Given this list of marker genes ATR, PCNT, ERCC6, SRCAP, ERCC8, EIF2AK3 (eukaryotic translation initiation factor 2 alpha kinase 3), TRPS1, TONSL, PCYT1A, here is a description of the gene set: Sclerosis of the epiphyses, leading to an increased degree of radiopacity (white or ivory appearance) in X-rays. Ivory epiphyses Human Gene Set: HP_IVORY_EPIPHYSES species: Homo sapiens